The following is a description of a gene set: The directed movement of phosphate into, out of or within a cell, or between cells, by means of some agent such as a transporter or pore, by a mechanism dependent upon sodium ions. Mouse Gene Set: GOBP_SODIUM_DEPENDENT_PHOSPHATE_TRANSPORT species: Mus musculus, and this is the list of marker genes: Slc34a2, Cebpb, Slc17a1, Atf4, Cry2, Slc17a4, Slc17a8, Stc2, Slc34a1, Slc17a6, Slc17a7, Slc34a3, Sfrp4